Given this list of marker genes HCN4, MAGEA10, SH3BGR, FGF9, PGAM2, TM4SF1, DDO, SLCO3A1, ASB9, NR0B2 (NCBI Gene Id 8431), AIDA, ELOA2, IPO7, SERPINB10, EPHA7, FGL2, SCAF11, SOBP, FBP2, CALCR, TNFRSF9, MYH1, DHX58, SHC3, DHX35, STAG1, SEMG2, GTF3C2, CADM1, FGF13, TBL1XR1, CEBPZ, DEPTOR, SNHG20, RPLP2, PLXDC1, FBXO21, ZNF33B, IL13RA1, PTMA (prothymosin alpha), DCAF4, UBTF, BCL2L10, NUFIP1, SHMT1, TBXA2R, IMP4, CSF2, ADD3, CD28, RAB33A, RAP1GDS1, CYP39A1, BRCC3, PGRMC1, RDX, HLA-K, KCTD15, FBXO3, SSX2IP, KLK15, IL12B, POU4F3, SMARCAL1, MAGEC3, CAMK1D, DSC1, ACOXL, AGGF1, MRM1, BRS3, NOS3, DCX, PDE1A (NCBI Gene Id 5136), VTCN1, SLC25A24, GBA1LP, GPR45, KRT19, C1QBP, PPP2R3A, MCM2, SIX1, RXYLT1, CARF, SRD5A1, GMPR2, COQ8B, ALCAM, ASIC4, DKK2, BTC, MADCAM1, ANXA6, ITGA10, ZNF271P, ACADL, GJA4, OR7E24, KRTAP1-3, ASF1A, TAP1, SLC35D2, MAB21L4, NUTF2, IQSEC2, XRCC5, CUEDC1, GDF2, C22orf31, CLEC5A, FBN1, SPRING1, BTG2, IFNA10, PCDHA10, TBC1D1, GPM6B, RFPL3, RNF115, IFIH1, MSX2, LHX6, SP3, UNC93B1, OXCT2, DAPK2, TUBB7P, GNAT2, RRAGA, PHLDA3, SET, BPY2, FLRT3, SCUBE3, TKTL1, SLC1A6, GJC1, SSBP3, GDI2, STXBP5L (syntaxin binding protein 5L), SLC25A22, ZNF532, HNRNPK, SLC10A2, GABBR2, FBL, SEMA3E, CHRNA9, DERA, E2F2 (NCBI Gene Id 1870), SCGN, OCM2, OSBPL7, MAGEC2, RNF144A, MRC1, S1PR5 (NCBI Gene Id 53637), KHDRBS2, KIF22, PDLIM2, MYBL1, MTNAP1, ALG6, GSDMB, NUDT13, ZNF682, TNFSF18, TRIM32, HRC, EDIL3, SPRYD7 (NCBI Gene Id 65073), INHBB, SPTBN5, CBARP, CCDC85B, ABCD3, DPYD, EPN3, PUS3, KIAA0586, CTSF, AFP, FAM3C, SNX7, LIPC, SSX5, CCDC51, APOBEC2, RASSF8, IL11, PRKCZ, LIMK2, BBOX1, ARHGEF38, KLHL21, USP39, RNASEH2A, here is a description of the gene set: Genes down-regulated in thymus subcapsular cortical region versus the whole cortex. from publication Griffith AV, Fallahi M, Nakase H, Gosink M, Young B, Petrie HT (PMID 20064453) Human Gene Set: GSE18281_SUBCAPSULAR_CORTICAL_REGION_VS_WHOLE_CORTEX_THYMUS_DN Interaction of hematopoietic progenitors with the thymic stromal microenvironment induces them to proliferate, adopt the T cell fate, and asymmetrically diverge into multiple T lineages. Progenitors at various developmental stages are stratified among different regions of the thymus, implying that the corresponding microenvironments differ from one another, and provide unique sets of signals to progenitors migrating between them. The nature of these differences remains undefined. Here we use novel physical and computational approaches to characterize these stromal subregions, distinguishing gene expression in microdissected tissues from that of their lymphoid constituents. Using this approach, we comprehensively map gene expression in functionally distinct stromal microenvironments, and identify clusters of genes that define each region. Quite unexpectedly, we find that the central cortex lacks distinctive features of its own, and instead appears to function by sequestering unique microenvironments found at the cortical extremities, and modulating the relative proximity of progenitors moving between them. species: Homo sapiens